The following is a description of a gene set: Mouse Gene Set: CUI_LANGERHANS_IFNB_RESPONSE_UP from publication Cui A, Huang T, Li S, Ma A, Pérez JL, Sander C, Keskin DB, Wu CJ, Fraenkel E, Hacohen N (PMID 38057668) Cytokines mediate cell-cell communication in the immune system and represent important therapeutic targets. A myriad of studies have highlighted their central role in immune function, yet we lack a global view of the cellular responses of each immune cell type to each cytokine. To address this gap, the authors created the Immune Dictionary, a compendium of single-cell transcriptomic profiles of more than 17 immune cell types in response to each of 86 cytokines (>1,400 cytokine-cell type combinations) in mouse lymph nodes in vivo. A cytokine-centric view of the dictionary revealed that most cytokines induce highly cell-type-specific responses. For example, the inflammatory cytokine interleukin-1β induces distinct gene programmes in almost every cell type. A cell-type-centric view of the dictionary identified more than 66 cytokine-driven cellular polarization states across immune cell types, including previously uncharacterized states such as an interleukin-18-induced polyfunctional natural killer cell state. Genes positively differentially expressed in cell type: Langerhans upon treatment with cytokine: IFN-β in mouse lymph nodes in vivo. studied in species Mus musculus, and this is the list of marker genes: Rtp4, Stat1, Plcb2, Rigi, Ifit1, Arhgef26, Phf11d, Irgm1, Ifit2, Trim30a, Ifit3 (NCBI Gene Id 433243), Irf7 (NCBI Gene Id 54123), Ifitm3, Slfn5, Trim30d, Gcsh, Xaf1, Fastkd2, Oasl2, Ifi209 (NCBI Gene Id 98348), Patj, Ddx60, Ifi203, Nup42, Serpina3g, 9930111J21Rik2, Parp12, Isg15, Ifi206, Spef2